Given this list of marker genes Arrb2, Tgfb2, Arrb1, Tgfbr1, Gipc1, Tgfbr2, Tgfbr3, Tgfb1 (NCBI Gene Id 21803), here is a description of the gene set: studied in species Mus musculus TGFBR3 regulates TGF-beta signaling Mouse Gene Set: REACTOME_TGFBR3_REGULATES_TGF_BETA_SIGNALING